Given this list of marker genes Csf1, Fhip2b, Pcnx2, Arhgap18, Pgam1, Itgb8, Usf2, Zfp788, Nr2c2, Ubqln3, Ahi1, Bcl9, Srsf11 (NCBI Gene Id 74089), Ppp3ca, Impdh1, Gxylt1 (NCBI Gene Id 382997), Arhgef12, Elovl5, Elk4, Tln2, Ephb2, Sox5, Usp36, Itga5, Zfp790, Cnga4, Mtf1, Gm6878, Fermt1, Acot3 (NCBI Gene Id 171281), Pgrmc2, Tmem178b, Rb1, Slc25a12, Hipk3, Esr1, Nbl1, Myo18a, Gid4, Bltp3a, Gabrg2, Cnot6, Ppm1l, Frat1, Necab1, Mapkbp1, Gm16130, Psma1, Shisal2b (NCBI Gene Id 77803), Csde1, Camta1, Ntng1, Anks1, Ndor1, Krtap6-6, Hs3st3a1, Slc9a9, Ikzf2, Mtf2, Prx, Rbpj (NCBI Gene Id 791349), Taok1, Zeb2, Spsb1, Zc3h6, Ctsb, Amph, Nfya, Natd1 (NCBI Gene Id 24083), Msantd3, Acvr2b, Tmod1, Gab2, Coro7, Ptpre, Cavin1, Snx2, Plcb1, Tnpo1, Ezh2, Smurf2 (SMAD specific E3 ubiquitin protein ligase 2), Leprotl1, Olfm1, Ppp1r12a, Larp4b, Tbl1xr1, Qsox2, Kcnq5, Pacrg, Coq8b, Atg13, Macrod2, Ubiad1, Creb5, Smg1, Nexmif, Celf4, Smg7 (SMG7 nonsense mediated mRNA decay factor), Hspa9, Wdr47, Trim46, Nfat5, Gpatch2l, Nup160, Zdhhc20, Cd22, Mtif3, Tpd52l2 (NCBI Gene Id 99179, tumor protein D52-like 2), Snx27, Zmynd11, Ppargc1a, Garem1, Clasp1, Inpp5a, Cep350, Gtpbp2 (GTP binding protein 2), Nkd1, here is a description of the gene set: species: Mus musculus from publication Chen Y, Wang X (PMID 31504780) Genes predicted to be targets of miRBase v22 microRNA mmu_miR_12186_3p in miRDB v6.0 with MirTarget v4 prediction scores > 80 (high confidence targets). Mouse Gene Set: MIR_12186_3P